Given this list of marker genes RAF1, ERBB2, DAG1, COL6A1, PLEC, SOS1, NDRG1, MAPK3, DICER1, ADGRG6 (adhesion G protein-coupled receptor G6), ILK, HRAS, MED12, CNTNAP1, GPC1, ARHGEF10, LGI4, RELA, PPP3R1, NAB1, LAMA2, NF1, AKT1, LAMB2, EGR2, SLC25A46, NCMAP, ERBB3, CDK5 (cyclin dependent kinase 5), MAP2K1, PARD3, SH3TC2, AKT2, SIRT2, MAP2K2, PRX, SKI, NTRK3, POU3F2, SOD1, POU3F1, ITGB4 (integrin subunit beta 4), FA2H, MYOC, CDK1, GRB2, NTRK2, PALS1, NAB2, MAPK1, here is a description of the gene set: studied in species Homo sapiens Human Gene Set: GOBP_SCHWANN_CELL_DIFFERENTIATION The process in which a relatively unspecialized cell acquires the specialized features of a Schwann cell. Schwann cells are found in the peripheral nervous system, where they insulate neurons and axons, and regulate the environment in which neurons function.